Given this list of marker genes PCBD2, FUBP1, UBALD2 (UBA like domain containing 2), RAB5IF, SRPRA, RAB5C, F2RL1, KLF9, KCNS2, HSPE1, HNRNPA1L2, NCAN, IMPA2, LIN7C, BAG2 (BAG cochaperone 2), E2F1, NDUFC1, ROCK1, HDGF, CREB1, EBF3, PACRGL, TMX2, PDAP1, YME1L1, SIAH1, PAFAH1B1, MSL2, ETFBKMT, PRPS2, HSD3B1, IPP, SEMA4F, BZW2, SDHC, MICOS10, GOLIM4, QDPR, NABP1 (NCBI Gene Id 64859), CHEK2, NUDCD2, YIPF5, SET, PTGES3, AQP9, MRPS25, ITGB1BP1, CPSF2, RECK, ZRSR2, TRNT1, GMFB, UBE2E1, PSMC5, SFXN1, EIF3J, TIMM22, ARL4C, CMBL (NCBI Gene Id 134147), STRN, AMZ2, NDUFAB1, SFPQ, UNG, SEL1L, AGFG1, NDUFB2, RNF11, SORL1, STT3A, PSMC6, NHP2, FAM162A (family with sequence similarity 162 member A), MPC2, UBQLN2, MMUT, APP, SMN2, CETN3 (centrin 3), KCTD12, ITFG1, NDUFB3, CTNND2, ATP11A, ARL14EP, EOMES, IPO7, ZNF131, RAB18, CYCS (NCBI Gene Id 54205), DHX9 (DExH-box helicase 9), VOPP1, GK, SNRPE, SNX9, SNORA57, BCL2, VAMP4, VDAC2, RPIA, ATP6V0B, CDCA7L, NIFK, TAF1D, CACYBP, TRIM43, TM9SF3, SEC62, IRAK1, EID1, GNPNAT1, RNF141, AK6, SLC7A5, NPM3, NME1, IL10RB, PCGF2, VTI1B, DUSP19, LAGE3, MRPL9, SOS2, PPA1, PRKCA, CD55, TIAL1, TGOLN2, DYNLL2, UBL5, PCCB, ZFP62, MACIR, MRPS33, C3orf38, BYSL, PDCD2, WIPF1, MAGOH, C9orf85, MACROH2A1, NACC2, RAD23B, GPX1, PBRM1, GALK1, NOP16, ATP5PF (NCBI Gene Id 63498), PARK7, IGF2BP2, here is a description of the gene set: from publication Goldrath AW, Luckey CJ, Park R, Benoist C, Mathis D (PMID 15548615) Up-regulated in CD8+ T lymphocytes undergoing homeostatic proliferation (HP) versus the naive cells; these genes are not up-regulated versus effector or memory cell population. Naive T cells proliferate independently of cognate antigen when introduced into lymphopenic hosts. Lymphopenia-induced proliferation depends on low-affinity MHC/self-peptide complexes and on IL-7. To elucidate the intracellular signals mediating this proliferation, we analyzed changes in gene expression in naive CD8+ T cells at different times after their transfer into a lymphopenic environment. The genes induced in response to lymphopenia were largely an attenuated subset of those turned up by full antigenic stimulation, including genes related to cell cycling, whereas excluding genes specifically associated with effector activity. After the initial phase of proliferation in an empty compartment, the naive T cells adopted a stable pattern of gene expression similar to that of antigen-experienced memory cells. Thus, T cells proliferating in lymphopenic hosts do not exhibit a unique gene-expression profile, instead relying on traditional signals for this antigen-independent proliferation; this process ultimately results in differentiation to authentic memory cells. Human Gene Set: GOLDRATH_HOMEOSTATIC_PROLIFERATION studied in species Mus musculus